The following is a description of a gene set: Human Gene Set: GOBP_RESPONSE_TO_CISPLATIN Any process that results in a change in state or activity of a cell or an organism (in terms of movement, secretion, enzyme production, gene expression, etc.) as a result of a cisplatin stimulus. species: Homo sapiens, and this is the list of marker genes: NFKBIZ, RAD51, BOK, DDX11 (DEAD/H-box helicase 11), HMOX1, TIMELESS